The following is a description of a gene set: Human Gene Set: HP_PRIMITIVE_NEUROECTODERMAL_TUMOR Primitive neuroectodermal tumor studied in species Homo sapiens A tumor that originates in cells from the primitive neural crest. This group of tumors is characteirzed by the presence of primitive cells with elements of neuronal and/or glial differentiation., and this is the list of marker genes: LIN28B, YY1, PIK3CA (NCBI Gene Id 5290), MLH1 (NCBI Gene Id 4292), TGFBR2, MAPRE2, DICER1, RPS20, CASZ1, PDPN, MDM2, APC2, LUZP1, GDNF, KRAS, SPEN, CHEK2, SEMA4A (NCBI Gene Id 64218), CDKN2A, BRCA2, RUNX1, EDN3 (endothelin 3), GPC4, PMS2, GPC3, BRD4, PMS1, MSH6, FLI1, POLD1, KEAP1, RET, GABRD, BDNF, BMPR1A, MMP23B, RERE, PTPN11, POLE, NSD1, KIF1B, ATM, EPCAM, MYO1H, LMO1, SDHB, PHOX2B, ALK, RAF1, TP53, SKI, KCNAB2, MSH2, NUTM1, BRAF, HSPG2, TUBB, ASCL1, NF1, PRDM16, LBX1, PRKCZ, MYCN, MUTYH, PALB2 (partner and localizer of BRCA2), HACE1, UBE4B